Given this list of marker genes NOTCH1, PROM1, CD34, NES, ZFP42, KDM5B, EPAS1, TWIST1, KLF4, HIF1A, SOX2, BMI1, NANOG, EZH2, CD44, MYC, LGR5, ABCG2, POU5F1, CTNNB1, ZSCAN4, here is a description of the gene set: Human Gene Set: MALTA_CURATED_STEMNESS_MARKERS studied in species Homo sapiens Literature curated collection of genes marking normal and cancer stem cells. from publication Malta TM, Sokolov A, Gentles AJ, Burzykowski T, Poisson L, Weinstein JN, Kamińska B, Huelsken J, Omberg L, Gevaert O, Colaprico A, Czerwińska P, Mazurek S, Mishra L, Heyn H, Krasnitz A, Godwin AK, Lazar AJ, Cancer Genome Atlas Research Network, Stuart JM, Hoadley KA, Laird PW, Noushmehr H, Wiznerowicz M (PMID 29625051)